The following is a description of a gene set: Human Gene Set: GOBP_AXO_DENDRITIC_PROTEIN_TRANSPORT The directed movement of proteins along microtubules in neuron projections. species: Homo sapiens, and this is the list of marker genes: KIF5A, KIF5C, MAP1A, HSPB1, NETO1, DLG2, RAB27B, KIF5B, MAPK8IP3